The following is a description of a gene set: Genes up-regulated during adipocyte differentiation (adipogenesis). from publication Liberzon A, Birger C, Thorvaldsdóttir H, Ghandi M, Mesirov JP, Tamayo P (PMID 26771021) studied in species Homo sapiens Human Gene Set: HALLMARK_ADIPOGENESIS, and this is the list of marker genes: TKT, PHYH, ANGPT1, DHRS7B, GPAT4, CMPK1, STOM, NDUFB7, DRAM2, MRAP, REEP6, ATP5PO, GADD45A, RMDN3, RAB34, AK2, JAGN1, COL15A1, RREB1, TOB1, PEMT, NKIRAS1, ME1, AIFM1, MTARC2 (mitochondrial amidoxime reducing component 2), COQ9, ATL2, IDH3A, CDKN2C, MAP4K3, NDUFA5, GPD2 (glycerol-3-phosphate dehydrogenase 2), CD302, SPARCL1, YWHAG, ITSN1, PREB, MIGA2, SLC19A1, CIDEA (cell death inducing DFFA like effector a), FZD4, SORBS1, OMD, IMMT, PGM1, CYP4B1 (cytochrome P450 family 4 subfamily B member 1), DGAT1, RTN3, G3BP2, ADIPOQ, ACADS, PPP1R15B, TANK, PLIN2, CMBL, RETN, PDCD4, LAMA4, TST, ESYT1, DBT, DECR1, ACOX1, STAT5A, NMT1, PIM3, POR, CAVIN1, GHITM, ITGA7, ECH1, SUCLG1, PTCD3, SLC25A10, GRPEL1, PRDX3, DHCR7, COL4A1, SNCG, UQCRC1, SLC25A1, PHLDB1, MGST3, ATP1B3, SDHB, C3, GPX3, ELMOD3, LIFR, DNAJC15, ITIH5, APOE, UQCR10, FABP4, GPAM, ENPP2, COX8A, ALDH2, SLC5A6, LIPE, ACLY, NABP1, CRAT, SDHC, CD151, ADIPOR2, BCL6, ADCY6 (adenylate cyclase 6), CAVIN2, COQ5, SOWAHC, SCARB1, PFKL, ORM1 (NCBI Gene Id 5004), ADIG, RIOK3, ELOVL6, PPM1B, MYLK, ALDOA, PFKFB3, LPL, MDH2, ACAA2, AGPAT3 (1-acylglycerol-3-phosphate O-acyltransferase 3), BCL2L13, SCP2, PPARG, QDPR, CPT2, COQ3, IFNGR1, LTC4S, ANGPTL4, DHRS7, EPHX2, ETFB, REEP5, VEGFB, NDUFS3, ESRRA, COX7B, UCP2, IDH3G, UQCRQ, SSPN, FAH, CHCHD10, ARL4A, CYC1, ACO2, RETSAT, MTCH2, SLC1A5, BCKDHA, HSPB8, SLC27A1, MRPL15, DNAJB9, GBE1, MGLL, DLAT, GPX4, PEX14, UBQLN1, CAT, SLC66A3, SULT1A1, ARAF, ACADM, ABCB8, HIBCH, PTGER3, SQOR, LPCAT3, BAZ2A, TALDO1, RNF11, DLD (NCBI Gene Id 2654), CCNG2, LEP, ABCA1, SOD1, ACADL, NDUFAB1, UQCR11, COX6A1 (NCBI Gene Id 1337), ECHS1, IDH1, MCCC1, APLP2, SAMM50, GPHN, UCK1, HADH, DDT, UBC, CD36, CHUK, CS